Given this list of marker genes SCGB1A1, MUC5B, SAA1, LTF, TSPAN8, CLDN4, RARRES1, GSTA1, NCOA7, NDRG2, KLK11 (NCBI Gene Id 11012), MSMB, PIGR, CXCL8, AGR2, PRSS23, CP (NCBI Gene Id 1356), CD82, SPINK1, SLPI, MMP7, VMO1, RDH10 (retinol dehydrogenase 10), SERPINF1, TFF3, FMO2, AKR1C1, CD24, ELF3, TSPAN1 (NCBI Gene Id 113345), SCGB3A1, CFB, CXCL2, MDK, KRT19, LCN2, SAA2, KYNU, TNFSF10, S100A9, CXCL1, TGM2, C3, CTSC, CLU, IGFBP3, WFDC2, PDZK1IP1, BPIFB1, FAM3D, here is a description of the gene set: Genes upregulated in subsets of cells of a given type within various tumors studied in species Homo sapiens In this study, an extensive analysis was conducted to define meta-programs (MPs) capturing intra-tumor heterogeneity across a spectrum of tumor types. The approach utilized non-negative matrix factorization (NMF) to analyze each cell type separately within individual tumor samples. This involved the analysis of malignant cells, macrophages, fibroblasts, endothelial cells, epithelial cells, T-cells, and B-cells. NMF was executed with varying parameter values (K=4, 5, 6, 7, 8, 9), thereby generating 39 programs for each cell type per sample. Each NMF program was summarized by the top genes based on NMF coefficients.\nRobust MPs were then delineated for each cell type using a set of stringent criteria, including recurrence within the same tumor, similarity to programs in other tumors, and non-redundancy within a tumor. Subsequently, these robust NMF programs were clustered (per cell type) based on Jaccard similarity, leading to the identification of MPs associated with each cell type.\nTo enhance the quality of the MPs, a refinement steps were undertaken, involving the removal of MPs suspected of reflecting low-quality data (with an overrepresentation of ribosomal proteins or mitochondrial-encoded genes), single-study inclusion, or similarity to miss-annotated cell types. from publication Gavish A, Tyler M, Greenwald AC, Hoefflin R, Simkin D, Tschernichovsky R, Galili Darnell N, Somech E, Barbolin C, Antman T, Kovarsky D, Barrett T, Gonzalez Castro LN, Halder D, Chanoch-Myers R, Laffy J, Mints M, Wider A, Tal R, Spitzer A, Hara T, Raitses-Gurevich M, Stossel C, Golan T, Tirosh A, Suvà ML, Puram SV, Tirosh I (PMID 37258682) Human Gene Set: GAVISH_3CA_MALIGNANT_METAPROGRAM_23_SECRETED_2